The following is a description of a gene set: The outer membrane of a muscle cell, consisting of the plasma membrane, a covering basement membrane (about 100 nm thick and sometimes common to more than one fiber), and the associated loose network of collagen fibers. Human Gene Set: GOCC_SARCOLEMMA studied in species Homo sapiens, and this is the list of marker genes: COL6A1, SLC8A1, SGCB, NOS1AP, SLMAP, ALOX12, KCNJ11, SLC2A1, RYR3, CDH2, SSPN (NCBI Gene Id 8082), ANXA8L1, FKRP, SGCZ, PPP3CA, ANXA8, SGCE, SGCD, POPDC2, STAC3, PDE9A, CAV3, FLNC, STAC, ANXA5, CCDC78, ANK3, FLOT1, REM1, ATP2B4, SCN1A (sodium voltage-gated channel alpha subunit 1), DYSF, AKAP6, CACNA2D1, SCN1B, STAC2, AHNAK, SMPD4, SNTB1, ANK1, ATP1B1, AQP1, DES, KCNJ12, CACNA1C, SNTG2, FGF6, RYR1, SNTA1, DMD, BGN, SLC2A5, NCSTN, LAMP1, GHRHR, SLC8A3, OBSCN, ABCC8, DAG1, SGCG, BSG, PLEC, KRT19, CACNA1S, LAMA2, CLCN1, KCNJ2, STBD1, SRI, KRT8, FXYD1, BIN1, CASQ1, SLC27A6, PPP3CB, DLG1, CACNG7, SLC2A4, CORO1C (coronin 1C), CACNG8, NOS1, CACNG1, ANXA2 (NCBI Gene Id 792), CIB1, SLC38A2, PGM5, KCNJ3, RYR2, AHNAK2, SCN2B, POPDC3, PRKG1, SLC8B1, VCL, SGCA, ATP1A2, VCAM1, ATP1A1, SYNM, DTNBP1, CAMK2D, ITGB1, CACNB1, CACNB3 (NCBI Gene Id 784), CAPN3, CIB2, SCN5A (NCBI Gene Id 652341), PPP3R1, CACNG6, ACP1, COL6A3, COL6A2, UTRN, CACNA1D, DTNA, CACNG4, RDX, FGF13, CAVIN4, ANXA1, ANK2, KCNB1, MYOT, BVES, CACNB2, AQP4, KCNJ8, KCND3, OPRK1, MLIP, SLC9A1, RTN2, TRIM72, SYNC, ABCC9, PSEN1, KCNK2, SLC8A2, SLC30A1